Given this list of marker genes SEM1, RAD9B, BARD1, DNA2 (DNA replication helicase/nuclease 2), RAD9A, RAD51D, RAD51, RAD17, ATM, RMI1, HUS1, ATR, BRCA1 (NCBI Gene Id 672), EXO1, RAD50, RFC5, PALB2, WRN, RPA1, RFC3, RAD51C, RAD51AP1, RPA3, XRCC2 (NCBI Gene Id 7516), RAD51B, BRCA2, BLM, ATRIP, TOP3A, NBN, RFC2, TOPBP1, RMI2, RAD1, BRIP1, MRE11, RHNO1, RFC4, RBBP8, KAT5, RPA2, here is a description of the gene set: Diseases of DNA double-strand break repair (DSBR) are caused by mutations in genes involved in repair of double strand breaks (DSBs), one of the most cytotoxic types of DNA damage. Unrepaired DSBs can lead to cell death, cellular senescence, or malignant transformation.<br><br>Germline mutations in DSBR genes are responsible for several developmental disorders associated with increased predisposition to cancer:<br>Ataxia telangiectasia, characterized by cerebellar neurodegeneration, hematologic malignancies and immunodeficiency, is usually caused by germline mutations in the ATM gene;<br>Nijmegen breakage syndrome 1, characterized by microcephaly, short stature and recurrent infections, is caused by germline mutations in the NBN (NBS1) gene;<br>Seckel syndrome, characterized by short stature, skeletal deformities and microcephaly, is caused by germline mutations in the ATR or RBBP8 (CtIP) genes.<br><br>Heterozygous germline mutations in BRCA1, BRCA2 or PALB2 cause the hereditary breast and ovarian cancer syndrome (HBOC), while homozygous germline mutations in BRCA2 and PALB2 cause Fanconi anemia, a developmental disorder characterized by short stature, microcephaly, skeletal defects, bone marrow failure, and predisposition to cancer.<br><br>Somatic mutations in DSBR genes are also frequently found in sporadic cancers.<br><br>The pathways "Defective DNA double strand break response due to BRCA1 loss of function" describes defects in DSB response caused by loss-of-function mutations in BRCA1 which prevent the formation of the BRCA1:BARD1 complex.<br><br>The pathway "Defective DNA double strand break response due to BARD1 loss of function" describes defects in DSB response caused by loss-of-function mutations in BARD1, the heterodimerization partner of BRCA1, which prevent the formation of the BRCA1:BARD1 complex.<br><br>The pathway "Defective homologous recombination repair (HRR) due to BRCA1 loss of function" describes defects in HRR caused by loss-of-function mutations in BRCA1 that impair its association with PALB2.<br><br>The pathway "Defective homologous recombination repair (HRR) due to BRCA2 loss of function" describes defects in HRR caused by loss-of-function mutations in BRCA2 that impair either it association with SEM1 (DSS1), its translocation to the nucleus, its binding to RAD51, or its binding to PALB2.<br><br>The pathway "Defective homologous recombination repair (HRR) due to PALB2 loss of function" describes defects in HRR caused by loss-of-function mutations in PALB2 that impair its association with BRCA2/RAD51/RAD51C.<br><br>For review, please refer to McKinnon and Caldecott 2007, Keijzers et al. 2017, and Jachimowicz et al. 2019. Reactome Pathway: Diseases of DNA Double-Strand Break Repair species: Homo sapiens part of: Diseases of DNA repair